The following is a description of a gene set: Human Gene Set: GOBP_CELLULAR_RESPONSE_TO_ALCOHOL studied in species Homo sapiens Any process that results in a change in state or activity of a cell (in terms of movement, secretion, enzyme production, gene expression, etc.) as a result of an alcohol stimulus., and this is the list of marker genes: AIFM1, SMO, FOXO3, INHBA, RPS6, PRKD1, SCNN1A, SOD2, EFNA5, GRAMD1C, CES1, ANKRD13C, LRP6, FBP1, SFRP1, DYNAP, CCL21, LRP8, SCNN1G, ADCY8, ADCY1, MIR182, CYBB, GPR155, PTGDR, ADAM15, PTCH1, FOS, GLRA2, XRN1, AKAP8, HCN2, ADCY2, DNMT3A, DRD2, CYP7A1, ABCA1, BRCA1, ADCY3, ADCY5, CDH1, TP53INP1, P2RY4, RECQL5 (RecQ like helicase 5), GRAMD1B, MIR185, ACACA, GLRA1, LARP1, UCP1, GRAMD1A, DEFB104B, CREB1, OSBPL7, SCNN1D, NFE2L1, TNFSF4, AKR1C2, GNG2, INHBB, PTGER2, SPI1, LANCL2, ADCY6, GPLD1, TNC (tenascin C), ITPR2, DAG1, KLF9, PTGER4, P2RY6, KLF4, BTG2, CTNNB1, MLC1, PTGDR2 (prostaglandin D2 receptor 2), SGK1 (serum/glucocorticoid regulated kinase 1), SLC5A5, GNB1, MIR342, AHR, PRKAA1, SCNN1B, PTGFR, PRKCE, CTNNA1, AKT1, PIM3, GNAS, GNAI1, ADCY7, SPHK2, SLC23A2, CFTR, GOLPH3 (golgi phosphoprotein 3), SPIDR, PRKAA2, MDM2, MIR96 (microRNA 96), NPAS4, BLM, RAD51 (NCBI Gene Id 5888), CDK4, CCR7 (C-C motif chemokine receptor 7), CCL7, CCL19, FDX1, DEFB104A, AKR1C3, KLF2, JUP, MAP4K1